The following is a description of a gene set: Human Gene Set: MODULE_403 species: Homo sapiens DNA damage response., and this is the list of marker genes: CHD3, PCNA, WEE1, CDK2, TRUB1, FTCD (NCBI Gene Id 10841), MCM3, NEK2 (NIMA related kinase 2), RPA1, CCNE2, UNG, MCM6, PRKX, PLK1, FEN1, EREG, XRCC5, CDC20, CDK1, TFDP1, H2AZ1, RECQL4 (NCBI Gene Id 9401), TOPBP1, CENPA, MSH2, SNX11, TOP2A, PLK4, MELK, MYBL2, CCNB1, ATR, DPP7, XRCC3, E2F1, CDC25B, UBE2V2, G0S2, CDC45, CDK4, MKI67 (marker of proliferation Ki-67), KPNA2, VRK1, DTYMK, TK1, VPS50